Given this list of marker genes Socs6 (NCBI Gene Id 77635), Itga11, Acaa2, Usp14, Pkn2, Tead1, Pik3ca, Slc40a1, Sugt1, Vat1l (NCBI Gene Id 270097), Med26, Esp34, Elavl1, Cpne5, Sdad1, Fkbp1b, 9330159F19Rik (NCBI Gene Id 628860), Pgrmc2, Arhgdia, Map7, Chst1, Macc1, Fkbp15, Miga1 (NCBI Gene Id 99746), Emp2, Pgf, Zfp36l2 (NCBI Gene Id 12193), Mynn, Mitf, En2, Ro60, Oxsr1, Prtg, Hace1, Tex261, Ttl, Anxa11, Gltp, Miga2, Mapre1 (microtubule-associated protein, RP/EB family, member 1), Efcab14 (EF-hand calcium binding domain 14), Napb, Fam219b, Cbln4, Reep1, Cask, Rrbp1, Tbc1d9b, Rhoq, Rbm24, Zmat3, Far1, Morc4, Snip1, Luc7l2, Rbl1, Wdr41, Shroom3, Pabir2, Ryr3, Mylip, Snx4 (sorting nexin 4), Kcnj5, Rd3, Fbxo28, Ammecr1, Rufy2, Rnf144a, Rad17, Arg2, Otud1, Serinc2, Tarbp1, Slc31a1, Fnbp1l (formin binding protein 1-like), Rap2b, Slc16a1, B4galt1, Ptbp1, Pdcd7, Bmp6, Slc50a1, Hbp1, Spopl, Rab2a, Plin3, Bach2, Ell2, Gas1, Etv1, Zfand3, Zcchc14, Pakap, Zbtb5, Gria4, Stk36, Cacng5, Rbms1, Cpne8, Git2 (NCBI Gene Id 80654), Piezo2, Ptpn12, Vwa8, Fzd8, Rcbtb2, Cd164, Slc35b2, Nbeal2, Fsd1l, Myrf, Elk4, Gpr37, Limch1, Ist1, Sp3, Sh2b3, Zfp706, Vdac2, Nxt2, Ebf3 (early B cell factor 3), Cdk4, Krtap4-16, Mfsd14b, AU015228, Hhex, Pde3b, Acadvl, Wipf3, Zdhhc20 (zinc finger, DHHC domain containing 20), Top3a, Mapk4, Ccar1, Pptc7, Sigmar1, Fgfr2, Zfp654, Triap1, Jazf1, Osbpl3, Cpt1a, Sfrp4, Slc31a2, Sar1b, Rbms3, Eml6, Osbpl6, Zbtb39, Dctn4, Pcdh8, Lrig1, Lemd3, Abca2, Suclg2, Rock2, Plxnb2, Magea10, Dennd1b, Mtpn, Aldh6a1, Rffl, Slc1a4, Cntn1, Hipk3, Parp16, Cadps, Anxa7, Zeb1, Pde4a, Papolg, Otud4, Fbxo30, Kcnq5, Esrp1, Tcf3, Itpr3, Gabra6, Brwd3, Ide, Hmgxb4, Akt1s1, Slc25a13, Abhd3, Plekhm3, Katnbl1, Gli3, Rhbdl3, Rab9b, E2f6, Dnajc3, Zfp882, Cibar1, Mboat2, Gzf1, Casc3, Mapk14, Adcy1, Zfp869, Raver1, Igsf11, Rps6kb1, Samd4b, Rap2a, Zfp503, Dmxl1, Ak4, Chd1, Prpf40a, Elapor2, Nab1, Fam78b, Arhgap1, Cotl1, Jakmip3, Ccdc50, Wasf1, Prr5l, Gpr50, Prkx, Rock1, Cnn3, Dicer1, Capn6, Myo10, Rpia, Nkain2, Foxc1, Lysmd3, Csgalnact2, Zdhhc3, Mtmr2, Actb (NCBI Gene Id 11476), Flot2, Mkrn3, Fcer1a, Sox9 (SRY (sex determining region Y)-box 9), Chsy1, Capn2, Eml5, Gucd1, Alg2, Sp1, Esyt2, Rab11a, Slbp, Zkscan3, Atmin, Cdk6, Enox1, Ccdc198, Uba6 (NCBI Gene Id 66644), Epha3, Bahd1, Lpp, Sec61a2, Akap5, Lss, Akip1, Trim14, Abcc4, Map4k5, Tmem134, Rsu1, Nrp2, Slc4a7, Ralgps1, Srek1, Fermt2, Slc41a2, Chp1, Cbfb, Rnf216, Asb1, Septin10, Prkd1, Insrr, Ankfy1, Tm6sf1, Kcnj2, Ahnak, Aida, Hdac4, Ahr, Dnmbp, Fam78a, Itga6, Cyld, Marchf8, Prkaa2, Rwdd4a, Krt35, Rela, Nr3c2, Pawr, Selenoi, Irf2bp2, Slc39a9, Golm2, Sema6d, Yod1, Dennd4c, Yipf6, Mtdh, Ccdc6, Epn2, Pdcd6, Snx6, Nhlrc2, Rab34, Zfp608, Tacc1, Ascc2, Klf4, Ermp1, Sirt1, Antxr2, Rnf214, Rragd, Frmd8, Sertad3, Foxq1, Nup133, Mllt3, Myorg, Phtf2, Tmem45b, Elovl2, Osbp, Hepacam, Ptpn1, Fhip1a (NCBI Gene Id 229488), Rcor1 (NCBI Gene Id 28079), Acsl1, Vdac3, Cpsf6, Atp6v0a2, Elovl5, Rala, Amotl1, 2210408I21Rik, Cacnb2, Lrrc58, Ccdc117, Spry1, Jag1, Cep72, Pcsk6, Pea15a, Rnf128, Lonrf1, Sncaip, Tor3a, Paqr5, Lmna, Lcp1, Tpd52l2, Tmem178, Lpin1, Tm9sf1, Ahcyl1, Sash1, Cntn3, Nol4, Magt1, Rbm20, Zdhhc7, Adipor2, Mab21l4, Pik3c2a, Slc25a20, here is a description of the gene set: species: Mus musculus Genes predicted to be targets of miRBase v22 microRNA mmu_miR_6540_5p in miRDB v6.0 with MirTarget v4 prediction scores > 80 (high confidence targets). Mouse Gene Set: MIR_6540_5P from publication Chen Y, Wang X (PMID 31504780)